Given this list of marker genes Mri1, Mtrr, Slc25a10, Tst, Ado, Ethe1, Gadl1, Fmo1, Suox, Mpst, Mtap, Mat1a, here is a description of the gene set: Reactome Pathway: Sulfur amino acid metabolism part of: Metabolism of amino acids and derivatives species: Mus musculus electronically inferred by orthology from the curated human pathway This event has been computationally inferred from an event that has been demonstrated in another species.<p>The inference is based on the homology mapping from PANTHER. Briefly, reactions for which all involved PhysicalEntities (in input, output and catalyst) have a mapped orthologue/paralogue (for complexes at least 75% of components must have a mapping) are inferred to the other species.